Given this list of marker genes IGKV3-11, IGHV3-33, IGHV2-5, IGHV4-39 (immunoglobulin heavy variable 4-39), IGHV3-13, IGKV4-1, IGLV2-14, IGKV2D-28, IGKV1D-12, IGKV1-16, IGHV3-7, IGKV1-5, IGKV1-17, IGHV3-48, IGKV3-15 (NCBI Gene Id 28913), IGLV2-11, IGKV1D-33, IGKV2D-30, CD22, IGHM, IGHV2-70, IGHV3-30, IGKV2-30, IGHV1-46, IGHV3-11, IGHV4-34, IGLV2-23, LYN, IGHV3-23 (immunoglobulin heavy variable 3-23), IGHV1-2, IGLV3-27, IGKV5-2, PTPN6, IGHD, IGLV1-51, IGLV1-47, IGKV3-20, IGLC2, IGLV1-40, IGKV1-12, IGLV7-43, IGHV4-59 (immunoglobulin heavy variable 4-59), IGLV3-21, IGKV2D-40, IGLV2-8, IGLV3-19, IGKV1-39, IGKV1D-39, IGLV6-57, IGKV3D-20, IGKV1D-16, IGHV1-69, IGKV1-33, IGLV3-1, IGKV2-28, IGLV3-25, IGLC3, CD79A, IGLV1-44, IGHV3-53, CD79B, here is a description of the gene set: CD22 mediated BCR regulation species: Homo sapiens Human Gene Set: REACTOME_CD22_MEDIATED_BCR_REGULATION